Given this list of marker genes NOTCH1, VPS13D, MAPK8IP3, AP5Z1, TRIM37, IPO11, RGPD2, LONP2, LMAN1, EGR2, SLC35D3, SFN, RFFL, PEX7, WLS, VPS41, B3GAT3, COMMD1, RAB6D, USO1, NUP62, NSG1, CDK1, MON1B, AP1G2 (NCBI Gene Id 8906), FLNA, RANBP2, SAMM50, TOMM22, HSP90AA1, TMED1, SORT1, RAB21 (NCBI Gene Id 23011), SNX11, PEX13, ARL6, FAM53C, CLTCL1, NDUFA13, RAB7A, TNPO1, RIMS1, CD36, UBE2J1, CTTN, OS9, GNPTAB (N-acetylglucosamine-1-phosphate transferase subunits alpha and beta), XPO5, STRADA, AP3D1, AP2A2, VPS8, IL1B, TARDBP, SEC13, SURF4, TIMM10, ABRA, RHBDD1, SCRIB, RAB1C, COPG1, ARL1, RANBP3, PIK3R2, TIMM50, GPIHBP1, RAB19, BCL3, CDK5, RANGAP1, TOMM70, NAPG, VPS37B, RUFY3, TSNARE1, HYAL2, SNF8, TOMM20L, STEEP1, APBA1, PEX12, RAB32, EHD1, DESI1, TXN, TMEM30B, CLU, RGPD3, C17orf75, KPNB1, TOMM6, STXBP1, CALR, FGF9, AP4E1, GRPEL1, AKAP5, ARL4D, PEX19 (NCBI Gene Id 7835), HEATR3, RFTN1, POM121L2, C2CD5, VPS13A, RAB29, MED1, ARFRP1, TENM1, JAK2, MON1A, NUP188, NSF, SIX2, RAB5B, RPH3A, AP1M2, LAMP2, PPP3R1, E2F3, SIRT7, NAPB, SEC23B, IL33, RAB1B, MVB12B, PSEN1, RIC1, CAMSAP3, VPS37C, HERPUD1, CABP1, VTI1A, EXOC6, OAZ2, SRPRA, GRIP1, UHMK1, AKIRIN2, TGFBRAP1, MTCH2, TIMM10B, HSPA9, ATF2, KIF20B, PEX10, TOMM40, CDKN1A, RAB5C, KIF13A, VPS35, AP3M1, SNX8, NUP107, SCARB2 (scavenger receptor class B member 2), VPS37A (NCBI Gene Id 23687), CD81, TRAM2, DLG2, GRIPAP1, VPS37D, SPRN (NCBI Gene Id 503542), EXPH5, PPP1R10, YWHAB, SEC61A2, TNPO2, VPS26B, RGPD6, ARF1, AP2S1, HERC2, VPS29, RAB8A, IFNG, TMCO6, SNX9, HDAC6, VPS11 (NCBI Gene Id 55976), CDH1, NXT1, PIK3R1 (NCBI Gene Id 5295), MAP1LC3C, PIK3R4, CHRM1, STX8, CCHCR1, LMNA, UBAC2, PTTG1IP (PTTG1 interacting protein), DNAJC19, PRP4K, RPH3AL, RAB8B, SYK (NCBI Gene Id 6850), CHP2, NAGPA, ARFIP2, STX7, SEC61B, RPL23, RANBP3L, STRADB, GLI3, NCOA4 (nuclear receptor coactivator 4), SEC24B, BCR, TMEM30A, PPP3CA, ARF4, ERP29, STAT3, SAR1A, RAB6A, XPO7, IPO8, ING1, NF1, RBM22, MVB12A (NCBI Gene Id 93343), TRIM23, TP53, NFKBIA, PRICKLE1 (prickle planar cell polarity protein 1), GGA1, SPG11, SP100, NUP88, RAN, MLPH, APOD, VPS16, SYNRG, MTX2, SYTL5, SEC24C, TRIM28, CHM, SEC24A, TGFB1, ATP13A2, POM121B, POM121C, RAB5A, CWH43, EMD, ADAR, PDCD10, EP300, COPB2, SYVN1, SCFD2 (NCBI Gene Id 152579, sec1 family domain containing 2), STAM, NUP85, OAZ1, GFAP, RAB38, PRKCD, NUP133, STXBP2, SEC23IP, RAB11A, ANP32B, CFL1, VAMP2, TRMT10B, RAB17, RAMP2, RILPL1, STX3, IPO4, STX5, STX1B, IPO13, VPS54, SIRT6, SNX5, COG3, VIPAS39 (NCBI Gene Id 63894), KPNA3, TIMM17B, CEP131, COPB1, ARF3, CLTC, PKD1, PKIA, TXNIP, XBP1, KPNA1 (NCBI Gene Id 3836), NR4A1, NDEL1, GCC2, RGPD8 (NCBI Gene Id 727851), PEX26, SNX10, KIF5C, KPNA5, ARL11, AHCYL1, GLP1R, TMED10, RILPL2, STX19, WDR11, AUP1, ATP6AP1, ARF5, ASPSCR1, STX18, AP3M2, TSC2 (NCBI Gene Id 7249), REEP2, EDEM2, SNUPN, FRAT2, ZC3H12A, RAB28, RTN2 (NCBI Gene Id 6253), AP1S2, GCKR, XPO4, TMED2, PEX16, GGA3, SNX2, CHP1, TIMM13, RAB23, NUP50, POM121, TOMM5, CD24, TIMM22, STX4, SNX13, IPO5, RAPGEF3, KPNA2, ARL5A, TRARG1, AP3B1, BCAP31, VPS33B, CLTB, COPA, TIMM23, SNAPIN, COPZ1, TIMM9, SLU7, IRGM, UBR5, VPS39, KPNA4, FRAT1, ARCN1, TSG101, HCLS1, RAB18, HDAC3 (NCBI Gene Id 8841), DERL1, PRKACA, SEC61G, MMP12, ASPH, CTDSPL2, BARD1, RAB43, SLC51B, RAB6C, RAMP1, VPS4A, ANGPT1, IPO9, PAM16, VPS13C, CDKN2A, PIK3C3, SNX1, MTCH1, EDEM1, NUP155, PICK1, CLIP3, SH3TC2, STX6, SYTL4, NPLOC4, VPS26A, HSPA5, ACD, SQSTM1, CTSA, EFCAB7, TRAM1L1, RABL2B (RAB, member of RAS oncogene family like 2B), NUP153, VPS36, MYRIP, PEX6, DNAJC27, SYTL3, SEC61A1, CAMK1, DRD1, VCP, BCAP29, NDP, KPNA6, PEX5L (NCBI Gene Id 51555), SEL1L, SYTL1, ARL14, FAM53B (family with sequence similarity 53 member B), EIF2D, HM13, ERGIC3, BAG3, PML, APPL2, RAMP3, STX11, XPO6, STX1A, TMED9, BECN1, AP4M1, SNX27, TIMM8A, CD74, TBC1D13, IFT22, AP1S1, ATG14 (NCBI Gene Id 22863), NUTF2, UBAP1, RHOB, HIKESHI, PARK7, LRRC7, PEX2, KPNA7, SEC16A, ARL5C, YWHAH, COPZ2, TIMM44, IFI27, ZFAND2B, UFM1, PCM1, SEC62, ABCA12, SHH, COPG2, RPGR, GRIP2, AKT1, ZFYVE16, GGA2, ZDHHC2, RAB31, MDM2 (MDM2 proto-oncogene), TIMM8B, SNX15, SNX16, TIMM21, SEPTIN8, AP2A1, NEDD4, GSK3B, FAF2, HSPA8, MAPK14, MDFIC, SEC24D, INSIG1, DERL2, VPS26C, ARL4A, SNX6, TLK1, EXOC6B, PKIG, IPO7, PEX1, HGS, RABL2A, TIMM29, NUP98, RAB27B, UNC93B1, PPM1A, PTPN11, NPM1, STX12, TMED4, TRAF3IP2, AP1G1, TNPO3, ARL5B, NUP93, SCFD1, PHB2, ARHGAP44, DERL3, SEC23A, NGFR, TMED5, STK3, RABL3, TOMM7, PCNT, FAM76B, PTPN1, EI24, TMED6, ICE1, SNX17, SMURF1, AP1B1, ELAVL1, CHML, SMO, NUP214, RAB1A, SIL1, ANKLE1, PLK3, GRPEL2, USP9X, DNAJC15, NAPA, EPM2A, LAPTM5 (NCBI Gene Id 7805), KIF5B, SYNDIG1, MIA2, UFD1, RAB14, RAB22A (NCBI Gene Id 57403), VPS18, MYO7A, SORL1, ARFGAP3, CRYZL2P-SEC16B, MTX1, ZPR1, ROMO1, PTPN23, STK4, STX17, KCNQ3, RAB20, UMOD, YOD1, PEX5, STAM2, APPL1, RGPD4, AFG2B, LCP1, RPAIN, DMAP1 (DNA methyltransferase 1 associated protein 1), RIMS2, RANBP17, SEC16B, RGPD1, VPS53, SUMO1 (small ubiquitin like modifier 1), CSE1L, OAZ3, STX2, HSP90B1, RIPOR1, TMEM129, PDCD6, NUP58, VAMP4, SVIP, SCG5, VPS25, TMED3, RAB41, CRY2, RAB3GAP2, SMAD3, ARFIP1, TMED7, FAM91A1, MYO6, M6PR, RANGRF, LRRK2, GNPTG, LARGE1, UBE2G2, GAS6, ADIPOQ, TUBA1A, ARL4C, KIF5A, ECT2, AP3S1, TECPR2, PRKD1, ZFAND1, NETO1, CEP290, SORCS2, SNX33, NPAP1, XPOT, STXBP3, ZIC1, APPBP2, SYTL2, SAR1B, IFT27, FAM53A, TIMM17A, VPS28, STX16, RANBP6, ARL17B, VPS45, PRR5L, ARF6, SEC63, AP3B2, XPO1, AP2B1, EIF4ENIF1, WASH3P, VPS33A, YWHAE, SIX3, TOMM20, BRSK2, SNX31, NUP42, JUP, LEP, TERT, SPAG17, ARHGEF2, AP4B1, VTI1B, CLTA, PEX14, AP3S2, MAP1A, RAB6B, AP1S3, COG7, CBLB, AGK, PEX3, TM9SF4, NUP35, RGPD5, TPR (NCBI Gene Id 7175), TRAM1, POLA2, BMP4, AP1M1, MAVS, ATP1B1, ERLEC1, HSPB1, NUP54, RAB24, SRP54, AP2M1, SUFU, STX10, MBTPS1, PTPN14, SELENOS, FERMT1, here is a description of the gene set: studied in species Homo sapiens Human Gene Set: GOBP_INTRACELLULAR_PROTEIN_TRANSPORT The directed movement of proteins in a cell, including the movement of proteins between specific compartments or structures within a cell, such as organelles of a eukaryotic cell.